The following is a description of a gene set: species: Homo sapiens Metabolic related genes that showed negative correlation with MYC expression in CRC tissues Our transcriptome analyses of paired normal and tumor tissues from 41 patients with colorectal cancer showed that metabolic reprogramming of colorectal cancer is caused chiefly by aberrant MYC expression, which induced at least 215 metabolic reactions by changing the expression levels of metabolic genes and transporter genes. Further, MYC negatively regulated the expression of genes involved in mitochondrial biogenesis and maintenance but positively regulated genes involved in DNA and histone methylation. Knockdown of MYC in colorectal cancer cells reset the altered metabolism and suppressed cell growth. Human Gene Set: SOGA_COLORECTAL_CANCER_MYC_DN from publication Satoh K, Yachida S, Sugimoto M, Oshima M, Nakagawa T, Akamoto S, Tabata S, Saitoh K, Kato K, Sato S, Igarashi K, Aizawa Y, Kajino-Sakamoto R, Kojima Y, Fujishita T, Enomoto A, Hirayama A, Ishikawa T, Taketo MM, Kushida Y, Haba R, Okano K, Tomita M, Suzuki Y, Fukuda S, Aoki M, Soga T (PMID 28847964), and this is the list of marker genes: PLCD3, NEU4 (NCBI Gene Id 129807), B3GNT5, FUCA1, CPT2, RETSAT, PPM1A, SLC22A18AS, SLC41A2, MKNK2, SLC22A5, PPARD, SLC35B3, HADHB, TNFRSF1A, PMM1, PLA2G10, PAFAH1B1, PIP5K1B, SLC35A3, GBA3, SMPD1, UGP2, SLC17A4, CD36, MKNK1, FAS, SLC16A12, SLC26A2, SLC35A5, PAFAH2, SLC37A2, RXRA, B3GNT2, SLC8B1, SLC31A2, SLC4A4, PLCD1, SLC22A18, SLC17A5, DHRS3 (NCBI Gene Id 9249), ACADS, ECI2, LDHD, UGT2A3, PCK2, SLC30A10, PLPP1, CDS1, ENPP6, SLC44A1, PAPSS2, SLC46A3, MAPK3, SULT1A4, SLCO2A1, SLC35D1 (solute carrier family 35 member D1), SLC26A3, ACSS2, PGM1, PIP4K2C, SLC1A1, SLC30A4, FABP2, TRAF6, SLC25A24, ACO2, B3GALT1, SLCO4C1, SULT1A2, ACAA1